The following is a description of a gene set: Human Gene Set: GOBP_ALTERNATIVE_MRNA_SPLICING_VIA_SPLICEOSOME studied in species Homo sapiens The process of generating multiple mRNA molecules from a given set of exons by differential use of exons from the primary transcript(s) to form multiple mature mRNAs that vary in their exon composition., and this is the list of marker genes: DHX9, HNRNPU, ESRP2, RNPS1, SRSF12, RBM15, HNRNPM, RBM24, CELF1, SFSWAP, SFPQ, ARB2A (NCBI Gene Id 83989), SRSF1, RBM17, PUF60, ARGLU1, BCAS2, SMU1, YTHDC1, DYRK1A, ZBTB7A, HNRNPUL1, STRAP, DDX5, MAGOH, RBFOX1, RBM25, CELF5, RBFOX2, TIA1 (TIA1 cytotoxic granule associated RNA binding protein), TRA2B, THRAP3, NCBP2, NOVA2, SRSF2, RBMX, NOVA1, RSRC1, NSRP1, RBM8A, RBM7, WTAP, HNRNPUL2, CELF2, KHDRBS3, RBPMS (NCBI Gene Id 11030), CELF3, RBM20, HNRNPL, THUMPD2, PTBP1, NCBP1, RBM4, SRSF6, SRSF9, RBM5, RBPMS2, KHDRBS2 (NCBI Gene Id 202559), SRRM4, CDK13, MYOD1 (myogenic differentiation 1), PQBP1, SRSF8, HNRNPA1, FMR1, SLU7, RBM15B, REST, DDX17, CELF6, SAP18, KHDRBS1 (NCBI Gene Id 10657), RBFOX3, CELF4, RBMY1A1, RBM47, RBM11, SCNM1